The following is a description of a gene set: Catalysis of the reaction: CMP-N-acetylneuraminate + alpha-N-acetylneuraminyl-(2->3)-beta-D-galactosyl-R = CMP + alpha-N-acetylneuraminyl-(2->8)-alpha-N-acetylneuraminyl-(2->3)-beta-D-galactosyl-R. studied in species Mus musculus Mouse Gene Set: GOMF_ALPHA_N_ACETYLNEURAMINATE_ALPHA_2_8_SIALYLTRANSFERASE_ACTIVITY, and this is the list of marker genes: St8sia4, St8sia6, St8sia1, St8sia5, St8sia2 (ST8 alpha-N-acetyl-neuraminide alpha-2,8-sialyltransferase 2), St8sia3